The following is a description of a gene set: Human Gene Set: REACTOME_APC_CDC20_MEDIATED_DEGRADATION_OF_NEK2A species: Homo sapiens APC-Cdc20 mediated degradation of Nek2A, and this is the list of marker genes: ANAPC4, ANAPC10, CDC16, MAD2L1, ANAPC1, ANAPC11, UBA52, ANAPC7, BUB1B, UBC, BUB3, UBB, UBE2S, ANAPC5, UBE2C, NEK2, RPS27A, CDC20, UBE2D1, CDC26, ANAPC16, CDC27, ANAPC15, UBE2E1, CDC23, ANAPC2